The following is a description of a gene set: Human Gene Set: GSE17721_POLYIC_VS_PAM3CSK4_4H_BMDC_UP studied in species Homo sapiens from publication Amit I, Garber M, Chevrier N, Leite AP, Donner Y, Eisenhaure T, Guttman M, Grenier JK, Li W, Zuk O, Schubert LA, Birditt B, Shay T, Goren A, Zhang X, Smith Z, Deering R, McDonald RC, Cabili M, Bernstein BE, Rinn JL, Meissner A, Root DE, Hacohen N, Regev A (PMID 19729616) mouse primary BMDCs were stimulated with tlr ligands and gene expression changes were profiled on Affymetrix arrays Genes up-regulated in comparison of dendritic cells (DC) stimulated with poly(I:C) (TLR3 agonist) at 4 h versus DC cells stimulated with Pam3Csk4 (TLR1/2 agonist) at 4 h., and this is the list of marker genes: CAMK2B, NDUFA9, SNAP29, KRT84, ITPRID2, UBE2R2, DCTPP1, USP15, CCND3, PAICS, TSC22D3, EIF4ENIF1, TAL1, PITPNM1, TEX9 (NCBI Gene Id 374618), CCR7, MGLL, ECHS1, SLIRP, NECTIN4, HBEGF, MESP2, SLC52A3, GYG1, MTFR2, RAMP3, SFXN2, BAG1, PTPN2, UBAC1, TPK1, MIA2, FAM117A, TLE6, GBP2 (NCBI Gene Id 2634), PSIP1, ATG3, TMOD2, TOPORS, CHMP4B, APOOL, ELMO1, TSPAN4 (tetraspanin 4), CCL5, TEFM, UGDH, NCKIPSD, TSPAN13, C6orf62, PDSS1, RPS21, MCM10, SH3BP2, ELK4, NEK7, SUMF1, MRPS26, HAT1, BCAS2, ATP5IF1, LIPA, PRR15, MAPK9, MRPL39, GTPBP2, CLIP1, SASH3, GPBP1L1, CEP15, SIAE, TCOF1, EXT1, OLFM1, SPN, SFMBT1, DOCK1, ZNF318, ASL, GLIPR2, ENDOG, CLEC4M, MCM7, IFI30, HASPIN (histone H3 associated protein kinase), APLP2, ARFGEF1, SUDS3, DNAJC10, KDM3B, USF1, EWSR1, BRDT, PEX3, SASH1, SH3BP1, RPS19, RPL38, PRCP, P2RX5, LAPTM4A, CCPG1, GRAMD2B, FANCL, MPST, IKZF1, PCYT1A, SMPDL3A, IP6K1, SARAF, ENPP2, RTCB, BAZ2B, TMEM106B, LAMTOR1, SORL1, DUSP6, USP1, PKIB, ATP6V1B2, CCNJ, AIF1, WARS1, SRPK2, MAPK13, VAMP8, MOV10, ATP6V1D, PCTP, PRNP, RHOU, SLC4A8, PARP1, TXNDC16, ZBTB8A, SLC26A3, RGS20, MYL11, SPOP, PXMP2, MOCOS, DPH6, CSNK1D, BLTP1, RACGAP1 (Rac GTPase activating protein 1), ERGIC1, SKIC2, SLC12A9, CDCA5, MALAT1, PIK3CD, TOR3A, PLPP2, PAPOLG, PI4K2A, ADAM23, CBR3, PLCL2, POLD1, CLEC5A, HAUS8, SDC3, MIX23, ACADM, BHMT2, STARD8, CEBPZOS, RAB9A, PTS, SSBP1, GRAMD4, BCAR3, SGK3, VPS72, TNFSF8, TSC22D1, CASP4, TFG, HNRNPUL1, INPP5D, PSMA4, CUL7, MSRA, NUP153, TEP1, VPS37B, PRTN3, HELZ2, CCNG1, KLF6, IL6R, SLC7A8, FAM89B, VRK2, RAB33B, RPP21 (NCBI Gene Id 95307), WASHC4, RBCK1, PSMB8, ECE2, HMGB1